Given this list of marker genes TPP2, LIPA, TNPO3, MED10, PLCG2, LARP4B, NACC1, ANO6, SAMSN1, EBP, PALS1, CAMK1D, REST, GNA12, SLX4, RABGGTB, PRIM2, WDR12, STIM2, CHD8, UPF2, BMAL1, MARVELD1, DCAKD, AHCY, STAG1 (NCBI Gene Id 10274), DDX10 (DEAD-box helicase 10), TUT1, CTDSP2, TSPAN5, MTDH, TGFBRAP1, AS3MT, FRYL, VAV1, MBNL1, UBE2Q1, RAP1GDS1, LRCH3, SETD1A, GBF1 (golgi brefeldin A resistant guanine nucleotide exchange factor 1), MRPL3, BYSL, THOC2, CSNK1D, PCCA, PHYH, SCARF1 (scavenger receptor class F member 1), SRP72, NSF, IP6K1, TAF2, HIF1A, GABPA, PI4K2A, SDAD1, HIPK1, GLG1, ENOX2, PTP4A1, ISY1, FBXO42, SNX27, GORASP2, ASCC2, ARAF, ACBD5, KARS1, HAT1, UBE4B, IQGAP3, CDC73, CREB3L2, AGPAT3, PIGQ, ADAM19, SLC25A5, COPG2, INTS3, CRYL1, SLC43A3, ALPK1, SEC24D, PLEKHB2, SMYD2, SMC5, APPBP2 (NCBI Gene Id 10513), PHF5A, SKIC2, SEC23B, TLE4, CLPTM1L, CIAO2A, RELL1, TK2, PRPF3, NCAPD3, GAK, NOC4L, EML4, CCT6A, DHDDS, TATDN2, AP2B1, ST6GAL1, FBXO33, PSMB7, MAPRE2, LRRC4 (leucine rich repeat containing 4), AGPS, TMEM39B, COPS3, TAF5L, EIF2AK4, HNRNPH2, PDE6D, PAN3, ELOA, DGKZ, NUDT13 (NCBI Gene Id 51055), NHLRC3, CD86, APP, CDK14 (cyclin dependent kinase 14), TCF12, SH2B3, HADH, NDE1, RARS1, POLD4, AKAP8L, POLDIP2 (DNA polymerase delta interacting protein 2), TTC13, RASGRP4, TCP1, ACD, ACIN1, VPS53, NCOA6, TMF1, PHF6, RRAGA, SEC23IP, FAM193A, BAZ1B, VCPIP1, METTL6, THOC5, LILRB4, CDC37, RNF144B, TUBGCP4, CUX1, KIAA0319L, GLO1, CAPG, SH3PXD2A, CABIN1, ADAMTS1, CUL1, RIPK1, DDHD1, TMEM167B (NCBI Gene Id 56900), SYNJ1, TSC1, PRKACB, ACTL6A, RUVBL1, SPAG5, HMGCR, OAZ2, IPO9, DLAT, SNX6, LIMA1, PRKCB, CSNK1A1, VPS26A, C6orf89, RSF1, RIPOR2, VPS13C, LONP2, LPCAT1, NOTCH2, FKBP1A (NCBI Gene Id 2280), here is a description of the gene set: from publication Billmann-Born S, Till A, Arlt A, Lipinski S, Sina C, Latiano A, Annese V, Häsler R, Kerick M, Manke T, Seegert D, Hanidu A, Schäfer H, van Heel D, Li J, Schreiber S, Rosenstiel P (PMID 21335489) NOD2 is an intracellular receptor for the bacterial cell wall component muramyl dipeptide (MDP) and variants of NOD2 are associated with chronic inflammatory diseases of barrier organs e.g. Crohn disease, asthma and atopic eczema. It is known that activation of NOD2 induces a variety of inflammatory and antibacterial factors. The exact transcriptomal signatures that define the cellular programs downstream of NOD2 activation and the influence of the Crohn-associated variant L1007fsinsC are yet to be defined. To describe the MDP-induced activation program, we analyzed the transcriptomal reactions of isogenic HEK293 cells expressing NOD2wt or NOD2L1007fsinsC to stimulation with MDP. Importantly, a clear loss-of-function could be observed in the cells carrying the Crohn-associated variant L1007fsinsC, while the NOD2wt cells showed differential regulation of growth factors, chemokines and several antagonists of NF-κB, e.g. TNFAIP3 (A20) and IER3. Human Gene Set: GSE22611_UNSTIM_VS_2H_MDP_STIM_MUTANT_NOD2_TRANSDUCED_HEK293T_CELL_DN Genes down-regulated in HEK293 cells expressing mutant NOD2: untreated versus muramyl dipeptide for 2h. species: Homo sapiens